The following is a description of a gene set: species: Homo sapiens Non-obstructive azoospermia Absence of any measurable level of sperm in his semen, resulting from a defect in the production of spermatozoa in the testes. This can be differentiated from obstructive azoospermia on the basis of testicular biopsy. Human Gene Set: HP_NON_OBSTRUCTIVE_AZOOSPERMIA, and this is the list of marker genes: TERB2, RNF212, TERB1, KASH5, TAC3, RPL10L (ribosomal protein L10 like), DAZ3, XRCC2, SPINK2, GNRH1, RBMY1A1 (NCBI Gene Id 8286), PROKR2, FGF17, GNRHR, FGF8, SOX9 (SRY-box transcription factor 9), NSMF, TEX14, CHD7, FBXO43, DAZ4, FGFR1, CATIP, TEX15, CT55, MSH4, MEIOB, DUSP6, MSH5 (NCBI Gene Id 4439), KISS1 (NCBI Gene Id 3814), KISS1R, SYCE1, WDR11, MOV10L1, CFTR, TDRD9, ZMYND15, SOHLH1, ZSWIM7, SPATA22, TEX11, DAZ2, SHOC1, FANCM, DNAH10, TSPY1, SPAG17, PNLDC1, SPRY4, DDX3Y, USP9Y, TAF4B, PDHA2, NR5A1, DAZ1, CCDC34, NHLH2, SYCP3, STAG3, TACR3, DNHD1, HS6ST1, NANOS1, PROK2, KLHL10